The following is a description of a gene set: Mouse Gene Set: MIR_7076_5P from publication Chen Y, Wang X (PMID 31504780) Genes predicted to be targets of miRBase v22 microRNA mmu_miR_7076_5p in miRDB v6.0 with MirTarget v4 prediction scores > 80 (high confidence targets). studied in species Mus musculus, and this is the list of marker genes: Serpinc1, Rnf216, Rasl10b, Dok4, Daam2, Nrbp1, Zfp703, Xylb, Cyfip2, Mpp7, Oas3, Mef2d, Cbl (NCBI Gene Id 12402), Slc2a4, Tef, Fam78a, Gm14325, Smarcd2, Mtcl2, Taok3, Tmem8b, Parvb (parvin, beta), Pfdn1, S1pr3, Nxn, Gm2026, Tgif2lx2, Prr14l, Rpgrip1l, Cacna1e, Diras1, Zfp710, Smarcd1, Mink1, Fscn1, Hspb7, Gm14296, 2210418O10Rik, Cblb, Spock2, Myl9, Kcnc3 (NCBI Gene Id 16504), Mllt1, Rph3a, Map6d1, Shisa6 (shisa family member 6), Ccdc82, Nbl1, Elavl3, Ctnnd1, Ptpa, Arf5, Atxn7l3, Ppard, Chdh, Bach2, Scamp4, Gm12185, Limk1, AI597479, Atp2a3, Cntn2, Ddx41, Tcp11l1, Ddb1, Spry4, A4galt, Herpud1, Rreb1, Gm14308, Gm14434, Zfp385a, Tnfsf13, Nos1, Cry2, Eda, Gm5938, Elavl1, Crtc1, Kif2c, Spopl, Mmab, Tspan11, Zfp385b, Sec62, Ctdsp1, Tnrc18, Vamp2, Rab3d, Dusp3 (dual specificity phosphatase 3 (vaccinia virus phosphatase VH1-related)), Iqsec3, Kdm6b, Nfasc, Epb41l4b, Septin5, Pgs1, Vat1, Erv3, Adgrl1, Klrg2, Trim3, Mlst8, Asic1, Nfic, Cacna2d1, Nectin2, Gmeb2, Gpd1, Cenpb, Leng8, Celf3, Myrf, Slc6a8 (NCBI Gene Id 12911), Hip1, Scamp5, Trim27, Stat3, Pip5k1c, Pou2f2, Meis2, Tmem104, Nfam1, Nfix, Hepacam, Kcnj5, Gpx5, Kirrel3, Pde4a, Kdm5c, C1qtnf6, Capn8, Nmnat2, Apba1, Spib, Tbc1d16, Srrm4, Smchd1, Zcchc24, Lamc3, Rbm28, Hs6st1, Erf (Ets2 repressor factor), C1qtnf1, Nacc1, Arid1a, Elk1, Tpbpa, Nav1, Nkd1, Cyth1, Twf2, Bsn, Brinp2, Nf1, Gm14322, Sox13, Trhde, Ankmy2, Tmem164, Ucn3, Ywhae, Cnot3 (CCR4-NOT transcription complex, subunit 3), Nova2, Ngfr (NCBI Gene Id 18053), Adap1, Tspan2, Serpinf2, Gnao1, Tnfsfm13 (tumor necrosis factor (ligand) superfamily, membrane-bound member 13), Sema5a, Prdm16, Tpm2, Atxn1, Castor2, Dnmt3a, P2rx7, Gm4724, Phf20l1, Tgif2lx1, Ephb4, Sptb, Ptgdr2, Epha8, Dennd1a, Fbxo41, Hectd4, Gprin1, Hsbp1l1, Tob2, Clstn1, Angel1, Sdccag8, Wfdc5, Zc3h18, Hlf, Vsx2, Gng7, Bak1, Ppp1r9b, Igf2, Ccdc97, Pacsin1 (NCBI Gene Id 353072), Slco2b1, Sox12, Zfp983, Sox4, Nipal3, Celf5, 2900026A02Rik, Cacfd1, Dhdds, Ttyh3, 1700030J22Rik, Zfp593, Zfp827, Camk1d, Kif21b, Zfp58, Tmem63b, Mical2, Kif5a, Spindoc, Barhl1, Entpd7, Rogdi, Pou2f1, Bean1, Rab35, Nek7, Cyp2g1